Given this list of marker genes Ddc, Gde1, Btbd9, Tph2, Atp7a, Maoa, Atp2b2, Htr1a, Mdga1 (MAM domain containing glycosylphosphatidylinositol anchor 1), Cyp2d22, Rnf180, Grin2a, Fev, Tph1, Gch1, Chka, Pde1b, Spr, Maob, Aldh2, here is a description of the gene set: Mouse Gene Set: GOBP_PRIMARY_AMINO_COMPOUND_METABOLIC_PROCESS The chemical reactions and pathways involving primary amino compound. studied in species Mus musculus